The following is a description of a gene set: species: Homo sapiens Any process that increases the frequency, rate or extent of peptidyl-threonine phosphorylation. Peptidyl-threonine phosphorylation is the phosphorylation of peptidyl-threonine to form peptidyl-O-phospho-L-threonine. Human Gene Set: GOBP_POSITIVE_REGULATION_OF_PEPTIDYL_THREONINE_PHOSPHORYLATION, and this is the list of marker genes: MAPK1, SPHK1, CEMIP, IRGM, UBE2K, S1PR2, EGF, CHI3L1 (chitinase 3 like 1), WNK3, STOX1, TRIM6